The following is a description of a gene set: Human Gene Set: HP_SPONDYLOLYSIS Spondylolysis is an osseous defect of the pars interarticularis, thought to be a developmental or acquired stress fracture secondary to chronic low-grade trauma. Spondylolysis studied in species Homo sapiens, and this is the list of marker genes: LMX1B, RUNX2, FLNB, AGA, CTSK, ZFX, FLNA